Given this list of marker genes PPM1M, PDP1, PDP2, PPM1H, PPM1J, here is a description of the gene set: species: Homo sapiens Catalysis of the reaction: O-phospho-L-seryl- + H2O = L-seryl- + phosphate. Human Gene Set: GOMF_PYRUVATE_DEHYDROGENASE_ACETYL_TRANSFERRING_PHOSPHATASE_ACTIVITY